Given this list of marker genes Parp6, Tiparp, Parp12, Sirt4, Parp8 (NCBI Gene Id 69948), Parp11, here is a description of the gene set: Catalysis of the reaction: L-cysteinyl- + NAD+ = H+ + nicotinamide + S-(ADP-D-ribosyl)-L-cysteinyl-. Mouse Gene Set: GOMF_NADPLUS_PROTEIN_CYSTEINE_ADP_RIBOSYLTRANSFERASE_ACTIVITY studied in species Mus musculus